Given this list of marker genes FBXO5, PELI1, ACAA1, TXNIP, LAMC1, ARHGAP25, FEM1C, JAK1, GYG1, RAB6B, HACD4, PAN2, CENPN, EXOC6B, PHF19, MAFB, CENPI, SLC40A1, TNNI2, PEAK1, GTF2IRD2, UBR7, HEXA, CEBPG, PMS2, CDK17, STOM, AURKA, EZH2, CNNM2, SF3A1, TPD52, SH3GLB1, ARHGAP19, ING2, PLXNC1, GAB2, HLX, DKK2, TMUB2, RNF150, VAV3, FBXW4, NDNF, UPB1, CDK19, TUBA1B, NEDD4L, POGK, CAPRIN2, CNTN4, KANSL2, PCYOX1, LNX2, STIL, TSPAN13, STMN1, CCNG2, RCBTB2, MAN2A1, VSIG10, MAN1C1, PCK2, BCL2L11, ARAP2, PLXNA4, TJP3, DHX40, KIF23, PSIP1, UVRAG, CNPPD1, AKTIP, NCAPD2, AKT1, STX16, PARS2, GKAP1, RNF167, DENND5A, CKAP2L, FRMD6, SLC25A27, PTPRA, PHF3, IQGAP3, PPARD (peroxisome proliferator activated receptor delta), TGFBR2, SFT2D2, TMEM87B, GAPVD1 (GTPase activating protein and VPS9 domains 1), POMT1, NCAPG2 (NCBI Gene Id 54892), LRBA, TLR7, RELL1, PRR5L, C1orf21, XKR5, FUT11, GINS2, WDHD1, TYMS, CYBC1, CCNA2, RAD51, PDSS2, IL7R, SP4, POLK, INPP4A, PDE3B, CHAMP1, ZFYVE1, MBD4, FBXL8, BCLAF3, PMS1, DNMBP, ILDR2, PLEKHA1, GOT1, FNIP2, CEP44, SMC1A, HIPK2 (homeodomain interacting protein kinase 2, NCBI Gene Id 653052), SMYD3, PTOV1, MTA3, PITPNC1, ST3GAL2, KLHL8, CDCA3, BBS10, ABCD2, TUBB, ARRDC3, CASP3, TMEM71, EIF2AK3, LTC4S, NFIL3 (nuclear factor, interleukin 3 regulated), ALDH3A2, CYTIP, TLR8, TCEAL9, CUL4B, PRADC1, ZFAND2A, NEK2, UBE2H, VPS18, TDP2, LMO2, AP1B1, MPHOSPH9, DDB1, PURG, CBX5, CD93, PIP4K2C, IGF1R, PHF1, PCNA, MIS18A, PBK, DGKD, MIA2, TAF5, TBC1D17 (TBC1 domain family member 17), CLK1, DGKH, ESPL1, C19orf12, VPS26C, SAT1, CENPV, TSGA10, ABTB1, ATG2A, MFSD11, MID1IP1, CRYBG3, SSX2IP, ZNF668, CLASP2, HGSNAT, HJURP, METRNL, RBL1, PDGFC, MFSD9, MAPK3, ZNF358, S1PR1, TRIM25, LPAR6, RAMP1, FANCG, SOCS6, here is a description of the gene set: from publication Hervas-Stubbs S, Riezu-Boj JI, Gonzalez I, Mancheño U, Dubrot J, Azpilicueta A, Gabari I, Palazon A, Aranguren A, Ruiz J, Prieto J, Larrea E, Melero I (PMID 21108462) Human Gene Set: GSE17301_CTRL_VS_48H_ACD3_ACD28_IFNA5_STIM_CD8_TCELL_DN species: Homo sapiens IFN alpha mediated gene expression pattern. The effect of IFN alpha on human CD8 T cells responding to antigen (signal 1) and costimulatory signals (signal 2) provided by beads coated with anti-CD3 and anti-CD28 mAbs. This analysis examined the effects of IFN alpha on human CD8 T cells responding to antigen (signal 1) and costimulatory signals (signal 2) provided by beads coated with anti-CD3 and anti-CD28 mAbs. Magnetically sorted untouched CD8+CD45R0- T cells from three different donors were unstimulated or stimulated with IFNa2b or with anti-CD3/CD28 Beads alone or along with IFNa2b or IFNa5 for 48 hours. Individual mRNA samples were analyzed using HG-U133A 2.0 array gene chips. Genes down-regulated in CD8 T cells: control versus stimulated by IFNA5 and activated by anti-CD3 and anti-CD28.